The following is a description of a gene set: Genes down-regulated in CD4 T cells from lymph nodes: naïve versus day 28 after immunization. studied in species Homo sapiens Mice were immunized with PCC (pigeon cytochrome c). from publication Fazilleau N, Eisenbraun MD, Malherbe L, Ebright JN, Pogue-Caley RR, McHeyzer-Williams LJ, McHeyzer-Williams MG (PMID 17529982) Human Gene Set: GSE7548_NAIVE_VS_DAY28_PCC_IMMUNIZATION_CD4_TCELL_DN, and this is the list of marker genes: MAT1A, LAS1L, CCN1, SPATA2L (spermatogenesis associated 2 like), FOXG1, TLX2, GATA1, SLC6A7, SUB1, PCBP3, CNR2, COX6A1, TAF13, B3GALNT1, MT1B, MAX, HNRNPUL1, MTERF4, CPNE6, FRMPD4, HR, MED14, FAM131B, KCNA4, LBX1, GART, GRM4, NBAS, LAMP3, CAMK2G, NCKIPSD, MEIS3P1, AAMP, NINL, POLR2I, PTPN14, KRT8, B3GALT4, DOHH, MAN2A1 (NCBI Gene Id 4124), TAF4, APBA1, RPL39L, TTYH2, GRIA1, DRAP1, FRMPD1 (NCBI Gene Id 22844), RASSF9, CR2, HPX, NKX2-8, TNNT1, BCL3, LINC03124, EPOR, COX7C, GNLY, EIF2S1, CHST3, DESI1, SPAG7, SMO, MC2R, APEX1, CBX4, CDK8, FCGR2A (NCBI Gene Id 90764), NHLH2, ZNF79, ADRA2A, ASB4, GPR39, SHMT2, XIAP, SCNN1A, MATN4, ZMIZ2, TCN2, NBL1, NCR1, TYRO3, CCNE2, CNTN1, PGLYRP1, GALNT2, ETV4, VIPR2, TMEM109, ZNF711, SPTBN2, NXPH4, CALB1, SARS1, MUC7, SAA4, SHOX, IL3RA, ADCY1, SAG, TMEM259, FOXN2, LINC00342, PCDHA3, GYS2, SNAI2, NDUFS3, ZNF280B, PKMYT1, IRF9, WASL, U2AF2, OXCT1, DNAH17, IZUMO4, ARHGEF1, JAG2, SCN1B, CALML3, STRN, ATP5F1B, AMH, AKR1A1, VENTXP7 (VENT homeobox pseudogene 7), ADPRH, ID1, LIMCH1, ARVCF, GABARAP, FOLR1, CPLX2, SLC2A2, ZNF197, KLHL23, HLA-DOA, PCSK7, TNNT2, MMP15, STX10 (syntaxin 10), ADIRF, SOAT2, SSR1, HRK (NCBI Gene Id 8739), SEM1, RFC2, DTX4, NTRK3, CEACAM1, FGF13, SCAMP3, PSMD4, SYNM, ICAM4, PUF60, IL12RB1, SGCG, HTR3A, SLN, DLGAP1, C1R, SPEG, CEP104, TCAP, EIF2AK2, OGG1, PDZK1, TNFSF12, EXOSC2, CTRL, MAFK, ZNF423, CCL15, IGHMBP2, IRF2, MTG1 (mitochondrial ribosome associated GTPase 1), DDX19B, ECI1, PFKFB2, MCF2, RNF216 (ring finger protein 216), MFN1, AKR1C4, ACOX2, CCN6, HDGF, SLC14A2, CKS1B, EIF3J, BBOX1, GHRHR, LAMA3, RALB, CCND1, TTLL12, ATP1A2, CUX1, CALCA, PMS2P11, ZKSCAN8